The following is a description of a gene set: part of: Glycosphingolipid metabolism electronically inferred by orthology from the curated human pathway Reactome Pathway: Glycosphingolipid catabolism This event has been computationally inferred from an event that has been demonstrated in another species.<p>The inference is based on the homology mapping from PANTHER. Briefly, reactions for which all involved PhysicalEntities (in input, output and catalyst) have a mapped orthologue/paralogue (for complexes at least 75% of components must have a mapping) are inferred to the other species. species: Mus musculus, and this is the list of marker genes: Smpd4 (NCBI Gene Id 77626), Neu4, Hexb, Psap, Neu2, Arsj, Arsg, Arsi, Sts, Hexa, Glb1l, Sumf1, Smpd1, Arsa, Sumf2, Neu1, M6pr, Gba1 (NCBI Gene Id 14466), Glb1l2, Glb1l3, Gba2, Neu3 (NCBI Gene Id 50877), Smpd2, Asah2 (N-acylsphingosine amidohydrolase 2)